Given this list of marker genes Tbl1x, Ncor2, Gps2, Ncoa1, Abca1, Rxrb (NCBI Gene Id 20182), Hdac3, Ep300, here is a description of the gene set: This event has been computationally inferred from an event that has been demonstrated in another species.<p>The inference is based on the homology mapping from PANTHER. Briefly, reactions for which all involved PhysicalEntities (in input, output and catalyst) have a mapped orthologue/paralogue (for complexes at least 75% of components must have a mapping) are inferred to the other species. studied in species Mus musculus part of: Signaling by Nuclear Receptors Reactome Pathway: NR1H2 and NR1H3-mediated signaling electronically inferred by orthology from the curated human pathway